Given this list of marker genes SUFU, DVL3, IFNG, STAC3, GDF2, PTEN, BIN1, FH, SPEN, CYP26C1, NELFA, CCDC22, CCM2, GLI2, SHOC2, ARL6IP6, TSC1, LZTR1, TRPM3, MYF6, MGAT2, SRP19, GNA11, MDH2, DIS3L2, SMAD4, HOXD13, FGF8, DPM1, ACVRL1, DNM2, CALR, TFAP2A, ASXL1, PIK3CA, NF1, ARID1B, LETM1, VHL, FGFR1, CAPNS1, NODAL, VPS35L, KIF1B, FBXO28, PIGG, ENG, GNA14, GNAQ, SDHB, CTSA, CPLX1, PDCD10, POR, MTOR, FGFR2, RRAS2, NF2 (NF2, moesin-ezrin-radixin like (MERLIN) tumor suppressor), KDM6B (lysine demethylase 6B), RET, RYR1, CREBBP, RBM8A (NCBI Gene Id 9939), MSL3 (MSL complex subunit 3), MAP2K2, BRAF, IDH1, MAX, ELANE, NSD1, GNPTAB, RNU4-2, MPL, NRAS, KRAS, GLI3, WNT5A, KLLN (killin, p53 regulated DNA replication inhibitor), RASA1, CLPB, SDHC, EIF2AK4, H4C5, SEC23B, DVL1, JAK2, DPYSL5, TEK, PTCH1, CCND1, APC2, AGGF1, CD96, CRELD1, CDON, SEC23A, KDR (kinase insert domain receptor), SHH, SDHD (NCBI Gene Id 91899), SMARCB1, NDP, SDHA, TBC1D24, USF3, EP300, MTMR14, THSD1, SDHAF2, SETBP1, DLL1, SRD5A3, ZIC2, CTBP1, HS2ST1, TSC2, SLC26A2, COQ6, GFI1, EPHB4, TCIRG1, TMEM127, DHCR7, NOTCH1, KRIT1, BMPR1A, GPC6, GAS1, ATP2B1, NSD2, KANSL1, TET2, ANTXR1, EXTL3, TBX2, SIX3, HRAS, DISP1, WASHC5, ESCO2, PTH1R, FZD2, TGIF1, PUF60, CRIPTO, SLC25A11, MAP2K1, PPP1CB, IDH2, FGFRL1 (NCBI Gene Id 54966), AKT1, RECQL4, FLT4, DLST, ATP6V1B2, FOXH1, here is a description of the gene set: Vascular neoplasm A benign or malignant neoplasm (tumor) originating in the vascular system. species: Homo sapiens Human Gene Set: HP_VASCULAR_NEOPLASM